The following is a description of a gene set: Catalysis of the reaction: UDP-galactose + N-acetyl-D-glucosamine = UDP + N-acetyllactosamine. species: Mus musculus Mouse Gene Set: GOMF_N_ACETYLLACTOSAMINE_SYNTHASE_ACTIVITY, and this is the list of marker genes: B4galt3, B4galt5, B4galt2, B4galt1, B4galt4